The following is a description of a gene set: from publication Bhattacharyya S, Deb J, Patra AK, Thuy Pham DA, Chen W, Vaeth M, Berberich-Siebelt F, Klein-Hessling S, Lamperti ED, Reifenberg K, Jellusova J, Schweizer A, Nitschke L, Leich E, Rosenwald A, Brunner C, Engelmann S, Bommhardt U, Avots A, Müller MR, Kondo E, Serfling E (PMID 21464221) Human Gene Set: GSE21063_CTRL_VS_ANTI_IGM_STIM_BCELL_NFATC1_KO_16H_UP species: Homo sapiens Genes up-regulated in B lymphocytes with NFATC1 knockout: control versus stimulated by anti-IgM for 16h. Triggering of B cell receptors (BCR) induces a massive synthesis of NFATc1 in splenic B cells. By inactivating the Nfatc1 gene and re-expressing NFATc1 we show that NFATc1 levels are critical for the survival of splenic B cells upon BCR stimulation. NFATc1 ablation led to decreased BCR-induced Ca++ flux and proliferation of splenic B cells, increased apoptosis and suppressed germinal centre formation and immunoglobulin class switch by T cell-independent antigens. By controlling IL-10 synthesis in B cells, NFATc1 supported the proliferation and IL-2 synthesis of T cells in vitro and appeared to contribute to the mild clinical course of Experimental Autoimmune Encephalomyelitis in mice bearing NFATc1-/- B cells. These data indicate NFATc1 as a key factor controlling B cell function., and this is the list of marker genes: UCP2, PHF23, SMIM23, MGMT, OXNAD1, KIAA1217 (KIAA1217), PSD4, UNC93B1, WASF1, AOPEP, NXF1, SLC66A3, TREX1, SLC7A4, GDF3, TRIP6, RGS17, EPHX1 (NCBI Gene Id 2052), GNB4, TPBG, NT5E, EXOC4, KLRD1 (killer cell lectin like receptor D1), XDH, CSNK1D, CNKSR3 (NCBI Gene Id 154043), FKBP5, ARF6 (NCBI Gene Id 63379), CCL4, ARL4C, VSIR, GIMAP6, SSBP4, TMEM43, LAG3, CASK, MGAT5B, NLGN1, TRIM66, CTSF, CLEC16A, MMRN1, TBXA2R, FBXO42 (F-box protein 42), S100A10, ITM2B, SERPINB8, TAFA3, FAH, SLFN12L, TSPAN13, PPFIBP1, UMOD, SH3BGRL3, NDUFB9, TNS1, MOV10, IGSF9 (NCBI Gene Id 57549), GLRX, SYT5, CORO6, INTS15, ANKRD46, GSKIP, ATOX1, FBXL7, FAS, PLA2R1, KLHDC8A, MYL6, PLD3, DUSP2, CNIH2, VGLL4, CTTNBP2NL, PLK2, KRT71, HTRA4, STOM, NLRP6, IL12RB2 (NCBI Gene Id 3595), NPC2, AK1, GBA1, PTGES, HLA-DMB, RTN1, BTD, CALHM5, ASB2, HOXC10, ARG2, ZFAT, ASB14, SSTR1, PLA2G10, FLYWCH1, TIMP1, SIGIRR, TEX11, GPR137, CTSD, OSR2, INTS7, JUNB, SNX20, P3H2, ARC, SLC34A2, S100A4, S100A13, SELPLG (selectin P ligand), IL10RA, ATP6V0A1, SAMD9L, ZBTB38, ARAP2, MAN2B1, AZGP1, CXCR3, TMEM260, TRAPPC8, NRN1, MAP3K10, RBMS1, ACOT7, PARP9, NDST4, THADA (NCBI Gene Id 63892), KLF2, ARHGAP42, BRMS1 (NCBI Gene Id 25855), EIF5A, KLRK1, NYAP1 (neuronal tyrosine phosphorylated phosphoinositide-3-kinase adaptor 1), LANCL3, FHL2, CA5B, MPEG1, MSI2, PIK3CG, PKP3, MGLL, AP5B1, COL14A1, CCR5, RPS6KA1, TRPV2, WDR91, LYPD3, ARHGEF16, TNFSF13B, NCOA1, MTFR1L, KCNMB4, ALDOAP2, AGPAT3, EHD3, PLK3 (polo like kinase 3), SNAP29, GABARAPL1, HTR1D (NCBI Gene Id 3352), IL10RB, CCDC81, CDC42BPA, IER5, CPQ, PAPLN, CCN4, TXNL4A, LRRTM1, CD48, CCL2, NEUROD2, AFF3, IZUMO1R, CACNB2, CASP6, MYO3A, SLC29A3, PTPN14, MPPED1, CTSA, AGTR1, SH3GL3, SLC28A2, RIPOR2, BSCL2, DGLUCY, TTLL10, FAXC, GLIPR1, SCGN, BST1, ABCG8, POLK, TRMO, GJA4, CASP4, BCL2L11